The following is a description of a gene set: Mouse Gene Set: GOBP_TRNA_PROCESSING species: Mus musculus The process in which a pre-tRNA molecule is converted to a mature tRNA, ready for addition of an aminoacyl group., and this is the list of marker genes: Pop7, Mettl2, Pus10, Tsen34, Hsd17b10 (hydroxysteroid (17-beta) dehydrogenase 10), Dus4l, Trmt9b, Qtrt1, Nsun2, Wdr4, Zbtb8os, Yrdc, B3gntl1, Trmt1, Trmt2b, Alkbh8, Sepsecs, Trmt44, Nat10, Trmt10c, Lsm6, Rtcb, Mettl1, Thada, Rpp25, Elp1, Mtfmt, Dus2, Clp1, Tyw5, Qtrt2, Adat3, Rpp14, Grsf1, Akt1, Trpt1, Trmt112, Rpp21, Osgepl1, Gon7, Elac2, Trmt13, Ssb, Thumpd1, Adat2, Ankrd16, Thumpd2, Ctu1, Trit1, Pop4, Dph3 (NCBI Gene Id 75408), Ftsj1, Rpp30, Aars1, Dus3l, Adat1, Trmo, Trmt10b, Ptcd1, Elp5, Trub1, Trmt11, Qng1, Trnt1, Tsen15, Elp2, Mocs3, Elp4, Trmt12, Alkbh1, Tsen54, Osgep, Dalrd3 (DALR anticodon binding domain containing 3), Pop5, Trmt10a, Elp3, Mettl6, Rpp38, Trmt2a, Dus1l, Tsen2, Cdk5rap1, Trdmt1, Thg1l, Thumpd3, Lcmt2, Trmt1l, Tyw1, Bcdin3d, Lage3, Gtpbp3, Kti12, Tprkb, Nsun6, Cdkal1, Pop1, Trmt6, Pus3, Rtraf, Dtwd2, Trp53rkb, Urm1, Prorp, Ctu2, Mettl8, Trmt61a, Tarbp1, Tyw3, Pus1, Pusl1, Nsun4, Nsun3, Dtwd1, Ddx1, Fars2, Mto1, Sars1, Trub2, Gtdc1, Trmt5, Trmu, Elp6, Rpusd4, Wdr6, Elac1, Rpp40, Rpp25l, Pus7